The following is a description of a gene set: Unusual skin infection Human Gene Set: HP_UNUSUAL_SKIN_INFECTION species: Homo sapiens A type of infection of the skin that can be regarded as a sign of a pathological susceptibility to infection., and this is the list of marker genes: PGM3, MVK, NCKAP1L, CD28, CARD9, IKBKG, CARD11, STK4, DOCK8, CARMIL2